Given this list of marker genes Galnt7, Smarcd1, Nufip2, Mrps2, Nadk2, Naa50, Ncs1, Sbk1, Rubcn, Nalf1 (NALCN channel auxiliary factor 1), Nol10 (NCBI Gene Id 217431), Vwde, Hapstr1, Gas7, Dcun1d1, Tmem130, Wdtc1 (NCBI Gene Id 277762), Arl2, Ammecr1l (AMME chromosomal region gene 1-like), Pml, Stim2, Med19, Diablo, Phf6, Tmem209, Peli3, Fgd5, Slc16a1, Mcoln2, Kif21b, Myrip (myosin VIIA and Rab interacting protein), Pcbp2, Irf2bp2, Ackr2, 9430015G10Rik, Fndc5, Mtcl2, Sema4d, Snx12, Scp2d1, Lsm12, Prdm15, Myoz3, Creb1, Fgf14, Lhx6, Baz2a, Ppp6c, Ralgapb (Ral GTPase activating protein, beta subunit (non-catalytic)), Twf1, Kpna1, Cdipt, 1700010I14Rik, Jakmip2, Zfp609, Tmem248, Il17rd, Gdnf, Exoc3, Sall4, Plpp1, Rab14, Psmg2, Fbln5, Abcc5, Gusb, Pim1, Zbtb40, Wnt2, Itgb8, Tspan11, Cetn2, Slc8a1, Tab3, Pycr1, Tbc1d5, Luzp1, Vps28, Mapk8, Ndc1, Errfi1, Glyctk, Ptprj, Gpn1, Tmem268, Gcc2, Tmem161b, Rnd1, Hmg20a, Hnrnpu, Eola1, Cdk6, Sox8, Mllt10, Naa15, Ptdss1, Lonrf2, Myo18a, Cpsf4, Mrtfb (NCBI Gene Id 239719), Purb (NCBI Gene Id 76437), Aph1c, Rapgefl1, Ppip5k1, Ccdc96, Tchp (NCBI Gene Id 77832), Ccdc167, Hykk, Stx8, Wnt3, Iqcg, Zfand3, Bcl2l11, Rab4b, Tbl1xr1, Fign, Fcho1, Pdcl2, Arvcf, Mrc2, Rcsd1, Tmem33, 0610010K14Rik, Cmtm4, Rexo2, Rtf1, Sec24c, Plagl2, C9orf72, Dll1, Ezh1, Zbtb41, Pdrg1, Enox2, Kbtbd2, Mapre1, Atp8a1, Oxr1, Rasgef1c, Crtac1, Usp20, Rexo1, Nmb, Lrrc1, Mecom, Pcdh20, Gpr63, Trim66, Sigmar1, 6430548M08Rik (NCBI Gene Id 234797), Akap13, Cd247, Zbtb8b (NCBI Gene Id 215627), Pter, Sun2, Gpd1, Leprotl1, Clint1, Eps8l1 (EPS8-like 1), Prr14l, Zfp710, Ddx17, D430041D05Rik, Neo1, Prtg (NCBI Gene Id 235472), Abtb3, Ldoc1, Qki, Tanc2, Naa30, Dolpp1, Afmid, Limd1, Nfatc2, Zbtb10, Rc3h1, Zbtb39, Nol7, Atp2b4, Cbl, Cnr2, Fchsd1, Cadm1, Cntnap1, Hspb1, Slc16a3, Kif7, Mlxip, Tgoln1, Hbegf, Pym1, Hr, Hoxa4, Fgfr1, Pgf, Ipo11, C5ar1, here is a description of the gene set: Genes predicted to be targets of miRBase v22 microRNA mmu_miR_761 in miRDB v6.0 with MirTarget v4 prediction scores > 80 (high confidence targets). Mouse Gene Set: MIR_761 from publication Chen Y, Wang X (PMID 31504780) studied in species Mus musculus